The following is a description of a gene set: studied in species Mus musculus Mouse Gene Set: GOBP_SUCKLING_BEHAVIOR Specific behavior of a newborn or infant mammal that results in the derivation of nourishment from the breast., and this is the list of marker genes: Phf21a, Derl2 (NCBI Gene Id 93680), Hand2, Ubr3, Cntfr (NCBI Gene Id 12804), Unc79, Grin1, Dach1, Aplp2, Pex13 (peroxisomal biogenesis factor 13), App, Ube2q1, Reg2, Helt, Oxtr, Gls, Pou4f1, Grin2b